Given this list of marker genes Dck, Cyp2j6 (NCBI Gene Id 13110), Kcnn3, Cdyl2, Spry4, 2410004B18Rik, Ctla4, Mreg, Snrpf, Ets2, Kmt5b, Nufip2, Gria2, Pex7, Acvr1c, Depdc1a, Adm, Wif1, Sypl1, Pbx3, Lrrcc1, Angptl7, Rundc3a, Ikzf1, Vma21, Sp2, Id4, Gdi2, Potefam3e, Myct1, Bnip2, Galnt7, Grm5, Hoxa10, Atp2b4, Arid4b, Ldb2, Aebp2, Sumo2, Baz2b, Ackr3, Snu13, Qrsl1, Alkal1, Atp11c, Azin1, Spire1, Creb3l1, Hapln1, Efr3a, Rheb, Tmx1, Bmpr1a, Slc39a12, Gtpbp2, Krit1, Adck1, Acbd5, Itgb2, Bahcc1, Snx25, Dicer1, Daam2, Col4a3, Atp11b, Ccdc126, Naf1, Ubr3, Kdm4b, Osbpl8, Taok1, Chac2, Sf3b1, Dcun1d1, Nipbl, Mitf, Nek7, Zfp292, Vat1l, Tmem168, Abi1, F2rl3, Cep97, Gtf3c3, Blzf1, Adamts16 (NCBI Gene Id 328284), Tmco3, Sema3c (sema domain, immunoglobulin domain (Ig), short basic domain, secreted, (semaphorin) 3C), Syvn1, Smg8, Atrn, Mc2r, Zfp507, Cyp26b1, Phc3, Hycc2, Csrnp3, Csnk2a1, Stox2, Jmjd1c, Sim1 (single-minded family bHLH transcription factor 1), Taf6, Tenm3, Bet1, Xk, H3f3b, 9330159F19Rik (RIKEN cDNA 9330159F19 gene), Atad2, Nr1d1, Fem1c, Dlat, Itpr1, Cacnb4, Kcna2 (potassium voltage-gated channel, shaker-related subfamily, member 2), Kmt2c, Mstn (NCBI Gene Id 17700), Armc1, Hsd3b1, Arih1, Ccn2, Spata6, Naa15, Ankrd12, Tut4, Anks1b, Arf4, Tab3, Six1, Irf6, Rgmb, Zfp987, Rnf138, Zmym3, Pdhx, Slc5a7, Nab1, Selenoi, Zbtb6, Atosa, Csmd1, Mid2, Mycn, Hivep1, Trpc1, Aox3, Ikzf5, Ust, Kmt5c, Rnf145, Sec63, Cntn4, Dagla, Cav2, Pcdh20, Ppp6r3 (protein phosphatase 6, regulatory subunit 3), Bcl2l11, Hpgd, Sos2, Lrrc39, Esrp1, Ythdf3, Hoxa5, Bbx, Atp2c1, Cinp, Vkorc1l1, Nck2, Yy1, Rock1, Lmo3, Smpd3, Ebf3, Sowahb, Trim33, Sgms1, Marchf6, Frg2f1, Lnx1, Phlpp1, Paip2, Rbm27 (RNA binding motif protein 27), Cflar, Ap1b1, Myf5, Hnf4g, Fgf12, Tm9sf2, Pja2, Cirbp, Mecom, Tomm7, Map3k8, Tbx2, Sptbn1, Abcd3, Hormad1, Cnr1, Ets1, Nxph2, Ccdc6, AI182371 (expressed sequence AI182371), Foxj3, Cep290, Kctd15, Btc, Triqk, Rora, Tasor, Agmo, Zfp985, Pde10a, Fsd1l, Sgip1, Wasf1, Potefam3a, Rab1a, Ddx46, Sh2d1a, Kif18a, Papss1, B3galt6, Cast, Slit3, Dach2, Bmi1, Lrp2, Dnajc6, Map3k13, Chic1, Kif3b, Golim4, Plpp3, Eea1, Eid2, Mbd5, Cul2, Zfp268, Esrrg, U2surp, R3hdm2 (NCBI Gene Id 71750), Tle4, Arl8a, Zfp711, Cul3, Lurap1l, Gata3, Fgl2, Ctbp2, Dyrk1b, Pabir2, Cul4a, Tardbp, Tshz1, Slc5a1, Sirt1, Axin1, Med13, Hmgn2, Rnd3, Jam2, Prdm6, Rbbp9, Entpd7, Mapk9, Mkx, Gcnt2, Aak1, Pi4k2b, Ugt2b5, Lin54, Txndc11, Dennd4a, Tob1, Sec24a, Yes1, Lrrc7, Id1, Arhgef7, Uchl5, Slit2, Acvr2a, Brwd3, Nr5a2, Gngt1, Tshz3, Erap1, Slk, Psmc3ip, Tmem33, Ppp2r5a, Csgalnact2, Hcfc1 (host cell factor C1), Acsl6 (acyl-CoA synthetase long-chain family member 6), Terb2, Cdc42ep3, Slc8a1, Sppl2a, Potefam3b, Zfx, Zcchc8, Nr3c1, Usp6nl, Lig4, Tec, Cd9, Bicd2, Bcl9, Kat2b, Mtf1, Slitrk2 (SLIT and NTRK-like family, member 2), Fmnl2, Spry2, Atrx, Klf2, Zfp770, Ptprm, Npat, Cecr2, Zxdb, Sox6, Abtb2, Ntf3 (neurotrophin 3), Satb2, Taok3, Tvp23b, Syap1, Rab6b, Dyrk1a, Eomes, Fzd7 (frizzled class receptor 7), Ptpn2, Gabrb2, Camta1, Nr4a3, Pde4b, Cdk17, Cntn3, Rab28, Klf13, Runx1, Pno1, Amotl1, Mapk1, Zzef1, Rictor, here is a description of the gene set: from publication Chen Y, Wang X (PMID 31504780) Mouse Gene Set: MIR_338_5P Genes predicted to be targets of miRBase v22 microRNA mmu_miR_338_5p in miRDB v6.0 with MirTarget v4 prediction scores > 80 (high confidence targets). studied in species Mus musculus